The following is a description of a gene set: species: Mus musculus Mouse Gene Set: REACTOME_ORC1_REMOVAL_FROM_CHROMATIN Orc1 removal from chromatin, and this is the list of marker genes: Psma2, Psmd14, Psmb6, Skp1, Psma5, Ubc, Psma6, Psmc3, Mcm6, Psmd2, Cdk2, Psmd3, Ccna1, Psmd11, Rps27a (NCBI Gene Id 78294), Ccna2, Orc2, Psmd1, Cul1, Psmd13, Psmb5, Orc5, Psmc4, Uba52, Mcm8, Psmc5 (protease (prosome, macropain) 26S subunit, ATPase 5), Psma1, Orc3, Psmb2, Cdt1, Psmb1, Psmb4, Psmd7, Orc4, Mcm4, Ubb, Adrm1, Psmb7, Uba52rt, Psmc6, Orc1, Rbx1, Psmd6, Psmc2, Psmc1, Mcm3, Psma7, Psmd12, Mcm7, Psma4, Skp2, Orc6, Psmd8, Cdc6, Mcm2, Psmb3, Mcm5, Psma3